Given this list of marker genes Ddb2, Usp24 (ubiquitin specific peptidase 24), Pcyt1b, Plk1, Prdm2, Srpx, Usp44, Pold1, Spi1, Dgkd, Apc, Agk, Mcm4, Eaf2, Mlh1, Abraxas1, Pla2r1, Spart, Blnk, Dnmt1, Fdxr (ferredoxin reductase), Fbxo4, Fzr1, Pole, Xpa, Pinx1, Fosl1, Anxa7, Eif4e, Becn1, Gpx7, Rcbtb2 (regulator of chromosome condensation (RCC1) and BTB (POZ) domain containing protein 2), Ppard, Fancf, Ambn, Eomes, Nsmce2, Uimc1, Trp63, Ctnnb1, Wwox, Cul9, a, Htatip2, Smg1, Aurkb, Brip1, Sirt2 (NCBI Gene Id 80489), Trim62, Cbx7, Apex1, Brca2, S100a4, Cdc37, Nf2, Nabp2, Plk3, Tlr3, Sod2, Trp53bp2, Tom1l2, Cdkn1a, Atm, Cep57, Wrn, Amy1, Msh2, Tgfb1, Stk11, Nbn, Brca1, Ptprj, Smurf2, Chfr, Msh6, Ptch1, Cxcr3, Grhl3, Lig1, Mdm2, Smad4, Blm, Pten, Mcm9, Hace1, Atr, Prdx1, Tsc1, Amelx, Glipr1, Rbm38, Stag1, Mmp7, Bhlha15, Mmp8, Ranbp2, Fen1 (NCBI Gene Id 14156), Ndrg2, Trim37, Dclre1a, Tgfbi, Met, Lzts1, Rb1, Slc33a1, Cop1, Fas, Hmgn1, Smarca4, Rint1, Tbrg1 (NCBI Gene Id 21376), Dkc1, Dph1, Klf14, Nrbp1, Fhit, Aurka, Pik3ca, Mad1l1, Acadvl, Nf1 (NCBI Gene Id 320618), Exo1, Myc, Dmtf1, Mir21a, Cdkn2a, Pml, Fancm (Fanconi anemia, complementation group M), E2f1, Bad, Cdkn2b, Men1, Mcm3, Tsc2, Atad5, Kras, Smarcb1, Tnk1, Pax6, Trp73, Prkar1a, Cdc20, Trp53, Neil1, Atp2a2, Mir146, here is a description of the gene set: species: Mus musculus Mouse Gene Set: MP_INCREASED_TUMOR_INCIDENCE from publication Motenko H, Neuhauser SB, O'Keefe M, Richardson JE (PMID 26092688) Mouse genes annotated to increased tumor incidence (MP:0002020) retrieved from the Mouse Genome Informatics database via MouseMine